The following is a description of a gene set: studied in species Mus musculus Mouse Gene Set: GOBP_PEPTIDYL_AMINO_ACID_MODIFICATION The alteration of an amino acid residue in a peptide., and this is the list of marker genes: Abi3 (ABI family member 3), Ppp1r15a, Rab6a, Itgb1, Itga5, Nf2, Stk4, Zfp592, Nos1, Pin1, Apoa1, Wee1, Prlr, Nlk, Zgpat, Jmjd6, Pdgfc, Eef1akmt3, Nsd1, Fer, Tssk4, Il9, Tlr4, Prnp, P4hb, Yes1, Galnt4, Ptprc (protein tyrosine phosphatase receptor type C), Gprc5b, Cspg4, Raf1, Jak3, Gpd1l, Dph2, Aplp2, Mettl18, Esco1 (NCBI Gene Id 77805), Stk11, Rptor, Adnp, Dkk1, Socs1, Spred1, Trpc6, Pias2, Prdx4, Ppic, Vps25, Bmp6, Clk3, Dohh, Prmt5 (protein arginine N-methyltransferase 5), Sumo2, Prkaca, Hipk2, Il7, Avp, Ripk2, Pdgfb, Uspl1, Ppif, Vipas39, Il15, Chek2, Cab39, Lif, Senp6, Eif4g1, Sptbn4, Sox4, Egr2, Adipoq, Nktr, Epo, Ep300, Ube2k, Dgkq, Zfp451, Tek, Itgb2l, Il2, Cdk10, Cntn1, Cntf (NCBI Gene Id 12803), Tnf, Lrp4, Myo3a, Zdhhc14, Cd74, Galnt2, Epha4, Jak2, Lilrb4a, Mul1, Btk, Csnk2b, Kmt2a, Lrrk1, Wnk3, Ppwd1, Klf15, Ptk6, Il6ra, Smtnl1 (smoothelin-like 1), Ggnbp2, Gfra1, Zdhhc18, Smyd3, Inpp5f, Il3, Rasd2, Gadd45a, Mknk1, Mad2l2, Pias1, Kmt5a, Ppihl, Dock7, Jak1, Mettl21c, Plk2, Stat5a, Nod2, Nrxn1, Ilk, Flt1, Nedd9, Spry2, Naa20, Lox, Pbk, Rab3b, Lep, Zdhhc1, Insr, Hyal2, P3h4, Sae1, Poglut1, Pkd1, Bcl2, Plpp3, Samsn1, Mboat4, Epm2a, Chchd4 (coiled-coil-helix-coiled-coil-helix domain containing 4), Pink1, Hmg20a, Apoa2, Atr, Zdhhc21, Zdhhc2, Shh, Htr2a, Tsg101, Egln2, Zdhhc17, Ranbp2, Socs4, Clk1, Rasa1, Socs3, Crlf1, Vegfa, Lipt1, Egfr, Sfrp2, Paqr3, Ctnnd1, Dok7, Zdhhc11, Vps33b (vacuolar protein sorting 33B), Fyn, Dyrk1a (dual-specificity tyrosine phosphorylation regulated kinase 1a), Tnks, Prkaa1, Trem2, Mark2, Prmt1, Lmtk2, Pias4, Ttll7, Ctnnb1, Il31ra, Eogt, Galnt16, Sphk1, Pkdcc, Mapk12, Rock2, Oxsr1, Abl1, Hrg, Tnk2, Sirt4, Ttbk2, Iqgap1, Setd3, Tssk1 (testis-specific serine kinase 1), Il22, Rack1, Nat8b-ps, Isl1, Ifih1, Plod3, Ulk1, Atm, Ttll6, Morc3, Hnf4a, Brsk2, Hck, Eef2kmt, Lck, P4ha1, Phip, Pdf, Zmiz1, Epha3, Cd24a, Fnip2 (NCBI Gene Id 329679), Asph, Akt2, Dclk1, Chi3l1, Pten, Senp7, Akap9, Aurka, Fnip1, Ntrk1, Nfe2, Il22ra2, Gata1, Csf3, Cblc, Wnt3a, Dph3, Semp2l2b, Kat7, Src, Il5, Dip2b, Galnt1, Ptpn22, Pdcl3, Fgfr1, Dusp22, Ppia, Ccl5 (NCBI Gene Id 20304), Hes5, Agbl3 (NCBI Gene Id 76223), Uhmk1, Ripk1, Met, Prkca (NCBI Gene Id 18750), Fgr, Bax, Il6, Il18, Fgfr4, Ntrk3, Ttll10, Tspan9, Zdhhc7, Il12rb2, Ptpn1, Ube2i, Fgf10, Mapk1, Dyrk3, Tmem102, Zzef1, Mapk13, Pdgfa, Rab3d, Bola3, Pikfyve, Uba2, Senp2, Ighm, Il34, Ptk2b, Prmt8, Smg1, Cdk2, Ogt, Clcf1, Gp6, Psen1, Mapk8, Myo3b (NCBI Gene Id 635238), Ntmt1, Sh2d1b2, Tssk2, Pdcd10, Trim6, Il4, Rnf212, Ahrr, Sumo1, Gnl3l, Fbxw7, Galnt3, Ero1a, Zdhhc15, Ttc36, Traf3ip1, Grem1, Nat8f7 (NCBI Gene Id 100043497), Eef1akmt1, Dvl2 (dishevelled segment polarity protein 2), Ptk2, Kat5, Arnt, Ercc6, Parp9, Fes (NCBI Gene Id 14159), Pdgfrb, Hsf1, Cdk5, Tgfa, Cbx4, Snta1, Hes1, Irgm2, Arrb2, Mapk14, Bdkrb2, Wdr5, Cass4, Akt1, Thbs4, Qpct (NCBI Gene Id 70536), Camk2b, Map3k12, Bag6, Dhps, Tnfrsf18, Galnt6 (NCBI Gene Id 58224), Zap70, Ndufab1-ps, Il12b, Plk1, Stx1a, Capn3, Oxr1, Hmg20b, Csnk1a1, Clec7a, Ptpn2, Pdgfra, S100a8, Agbl5, Vegfb, Spred2, Bag4, Ppih, Epha7, Golga7, Ttll9, Agt, Stk39, Gnl3, Ttll11, Unc119, Pecam1, Trpm4, Pak1, Suz12, Smo, Grk2, Tenm1, Pibf1, Reln, Cd44, Semp2l2a, Mlst8, Ppef2, Musk, Dnajc24, Psen2, Ndufaf7 (NCBI Gene Id 73694), Tgfb1, Il11, Hpx, Vtn, Igf1r, Setd6, Hbegf, Adam17, Top1, Txn1, Mapkapk2, Tbk1, Pml (promyelocytic leukemia), Osbp, Dph6, Areg, Zdhhc20, Fgfr2, Kit, Bst1, Rassf2, Map2k2, Zdhhc9, Efna1, Hnf1a, Kat2b, Nos2, Ptpn6, Ins2, Il12rb1, Prkcz, Cfap20, Cav1, Cdkn2a (cyclin dependent kinase inhibitor 2A), Trpc5 (NCBI Gene Id 22067), Tpgs1, Stox1, Inpp5j, Epha1, Eya1, Pak2, Loxl3, Wnk1, Tpst1, Nox4, Arl2bp, Agtpbp1, Adcy10, Gprc5a, Irf1, Tollip, Il6st, Hipk3, Cck, Ifnar1, Ppp2r5b, Lrrk2, Galnt13, Efemp1, Aatk, Gsk3a, Prkcd, Senp5, Smad7, Hrc (histidine rich calcium binding protein), Kat2a, Antkmt, Acvr1b, Ttll1, Snhg20, Cep41, Ddr2, Ppie (peptidylprolyl isomerase E (cyclophilin E)), Cd4, Ddr1, Fgfr3, Rela, Mlxipl, Fn3k, Cdk1, P3h2, Akt3, Braf, Tnks1bp1, Chek1, Abi2, Prkd1, Chmp6, Crebbp, Pin1rt1, Bak1, Pias3, Atpsckmt, Ern1, Sfrp1, S1pr2, Ndufab1, Poglut2, Desi1, Crebl2, Lilrb4b (leukocyte immunoglobulin-like receptor, subfamily B, member 4B), Prdm1, Agrn, Mark3, Irgm1, Gdnf, Csnk2a1, Lias, Errfi1, Nrg1, Nsmce2, Dph1, Wnt5a, Bank1, Igf1, Ttbk1, Sirt5, Lyn, Ttll4, Pxn, Poglut3, Cnot7, Pdgfd, Nek6, Ltk, Tfrc, Map3k10, Acvr1, Alk, Ncoa7, Sirt1, Clip3, Srpk2, Mgat5b, Ehmt2, Prkdc, Angpt4, Atat1, Cd80, Dph7, Prkce, Hdac4, Hcls1, Socs5, Ehd4, Cnksr3, Map3k13, Smc5, Setd7, Dclk2, Tnfsf18, Tnfrsf1a, Ip6k2, Rap2c, Itgb3, Ttll8, Blvra, Agbl4, Gsk3b, Tgfbr1, Tlk2, Setd2, Ppil1, Fcer1a, Il24, Fscb, Mettl21a, Plod2, Slc1a1, Zdhhc8, Vcpkmt, Senp1, Cdk5r1, Rangap1, Zdhhc3, Igtp, Ogfod1, Clk4, Topors, Fgf7, Mapk3, Camk2d, Mir301, Erbb4 (erb-b2 receptor tyrosine kinase 4), Cth, Dclk3, App, Atp13a2, Ifnb1, Ero1b, Cadm4, Ret, Tssk6, Map4k1, Il13, Plod1, Adh5, Fkbp10, Ndufaf5, Prkag2, Fam3c (FAM3 metabolism regulating signaling molecule C), Ppp2r5d, Nmt1, Pcbp2, Ptpn11, Syk, Umod, Mapkapk3, Cd3e, Zdhhc19 (NCBI Gene Id 385631), Hgf (NCBI Gene Id 15234), Ppig, Hdac9, Ctf1, Map6d1, Sirt3, Nmt2, Sh2d1b1, Abi1, Hax1, Gapdh, Bloc1s1, Pard3, Prkx, Metap2, Icam1, Agbl1, Ros1, Ikbke, Ttll3, Lipt2, Sumo3, Prkaa2, Ifng, Trim28 (tripartite motif-containing 28), Senp3, Mapkap1, Galntl6, Egf, Ppm1f, Abl2, Ikbkb, Ppid, Mylk2, Mapk7, Enpp2, Dip2a, S100a9, Lonp1, Camk2a, Trim38, Zmiz2, Rps6kb1, Il21, Fn3krp, Dph5, Hint2, Mif, Gcsh, Ncl, Tnfrsf14, Clk2, Cemip, Hhat, Kif3a, Prmt7, Clspn, Arhgef2, Crtap, Rwdd3, Etfbkmt, Itgb2, Ptger4, Ucn, Pck1, Zfyve28, Naa80, Dmtn, Spink1, Qpctl, P4ha2, Agbl2, Pdk3, Rps6ka2, Prkd2, Cav2, Loxl2, Ntrk2, Efna5, Ehmt1, Cad, Inpp5k, Ptprz1, Rock1, Ntf3, Mtor, Araf, Csf1r, Kitl, Zdhhc12, Ppib, Ptpn4, Nat8, Ttk, Cd40, Srms, Tbc1d24, Sirt2, Rap2b, Eef1akmt2, Fgf8, Cblb, Pcbp1, Slc35b3, Hipk4, Lilra5, Traf7, Mvp, Prdx3, Csf2, Blk, Hdac2, Brsk1, Hint1, Cnot9, Bdnf, Srcin1, Naa60, Oprd1, Atp7a, Rictor, Egr1, Bcar3, Nck1, Vkorc1l1, Slc35b2, Camkmt, Erbb2, Semp2l1, Bcl11a, Pfn2, Parp14, Angpt1, Lats1, Park7, Ttll5, Hdac6, Galnt11, Ggcx, Osm, Ephb2, Il12a, P3h3, Smyd2 (NCBI Gene Id 68639), Vkorc1 (vitamin K epoxide reductase complex, subunit 1), Neurl1a, Tpst2, Flt4, Nat8f1, Kdr, Il23a, Il9r (interleukin 9 receptor), Dyrk2